The following is a description of a gene set: Mouse Gene Set: GOMF_URIDINE_TRANSMEMBRANE_TRANSPORTER_ACTIVITY Enables the transfer of uridine, uracil riboside, from one side of a membrane to the other. studied in species Mus musculus, and this is the list of marker genes: Slc28a1, Slc28a2, Slc29a1, Slc29a2, Slc28a2b, Slc28a3, Slc29a3 (NCBI Gene Id 71279)